The following is a description of a gene set: studied in species Mus musculus The process in which a relatively unspecialized monocyte acquires the specialized features of a multinuclear osteoclast. An osteoclast is a specialized phagocytic cell associated with the absorption and removal of the mineralized matrix of bone tissue. Mouse Gene Set: GOBP_MULTINUCLEAR_OSTEOCLAST_DIFFERENTIATION, and this is the list of marker genes: Cd109, Sh3pxd2a, Oscar, Adam8, Tcta, Tnfrsf11a, Cd81, Dcstamp, Bbln, Sbno2, Ocstamp